Given this list of marker genes NR2C1, KLF2, TRIM16, CTBP2, ASXL1, here is a description of the gene set: Human Gene Set: GOBP_POSITIVE_REGULATION_OF_RETINOIC_ACID_RECEPTOR_SIGNALING_PATHWAY Any process that activates or increases the frequency, rate or extent of retinoic acid receptor signaling pathway activity. species: Homo sapiens